The following is a description of a gene set: Degradation of a cell nucleus by microautophagy. Human Gene Set: GOBP_PIECEMEAL_MICROAUTOPHAGY_OF_THE_NUCLEUS species: Homo sapiens, and this is the list of marker genes: ATG2B, ATG4C, ATG9A, ATG13 (NCBI Gene Id 9776), ULK1, ATG2A (NCBI Gene Id 23130), ATG4A, ULK3, ATG7, RB1CC1, ATG4B, ATG4D, ATG9B, ATG12, SNX30, ATG5, SNX7, ULK2